The following is a description of a gene set: Genes predicted to be targets of miRBase v22 microRNA mmu_miR_6936_5p in miRDB v6.0 with MirTarget v4 prediction scores > 80 (high confidence targets). from publication Chen Y, Wang X (PMID 31504780) species: Mus musculus Mouse Gene Set: MIR_6936_5P, and this is the list of marker genes: Slitrk4, Fam120b, Gabra3, Pitpnm3, Grem2, Zfp770, Zfp318, Slc7a6, Lingo2, Kbtbd2 (kelch repeat and BTB (POZ) domain containing 2), Mkrn2, Dpp10, Hsd11b2, Rsf1, Tmem106b, Pcbp2, Pes1, Zfp946, 2210408I21Rik, Dio2 (NCBI Gene Id 13371), Ikbkb, Aak1, Rxra, Slc66a2, Ddx3x, Aff3, Ccnk, Pum2 (NCBI Gene Id 80913), Gabpb2, Cd200r3, Exo5, Prlr, Amotl1, Lipa, Pcbp1, Ube2j2, Ssh3, Tmod2, Dcx